The following is a description of a gene set: Mouse Gene Set: GOBP_NEGATIVE_REGULATION_OF_CALCIUM_MEDIATED_SIGNALING studied in species Mus musculus Any process that stops, prevents, or reduces the frequency, rate or extent of calcium-mediated signaling., and this is the list of marker genes: Itpr1, Slc24a4, Cmya5, Homer2, Atp2b4, Actn3, Cd22 (CD22 antigen), Egln1, Siglecg, Fkbp1b, Mtor, Sla2, Chp1, Myoz1 (myozenin 1), Rcan1, Mapk7, Fhl2, Homer3, Gsk3b, Prnp, Myoz2 (NCBI Gene Id 80533), Tbc1d10c, Dyrk2